The following is a description of a gene set: studied in species Mus musculus Reactome Pathway: RIP-mediated NFkB activation via ZBP1 part of: ZBP1(DAI) mediated induction of type I IFNs This event has been computationally inferred from an event that has been demonstrated in another species.<p>The inference is based on the homology mapping from PANTHER. Briefly, reactions for which all involved PhysicalEntities (in input, output and catalyst) have a mapped orthologue/paralogue (for complexes at least 75% of components must have a mapping) are inferred to the other species. electronically inferred by orthology from the curated human pathway, and this is the list of marker genes: Myd88, Rela, Ikbkb, Nfkbib, Nfkbia, Nfkb2, Nfkb1, Nkiras1